The following is a description of a gene set: studied in species Mus musculus Mouse Gene Set: GOBP_NEGATIVE_REGULATION_OF_RESPONSE_TO_TUMOR_CELL Any process that stops, prevents, or reduces the frequency, rate, or extent of a response to tumor cell., and this is the list of marker genes: Ufl1, Il4i1, Ceacam1, Tgfb1, Ahr (NCBI Gene Id 193333), Klre1, Havcr2, Pdcd1, Muc4, Cd274 (CD274 antigen)